Given this list of marker genes GRM2, SRGAP2, SLC24A4, FRMPD4, RACK1 (NCBI Gene Id 90938), NR1D1, HMCN2, LHFPL5, MKKS, SLC38A7, KIF5B, GABRB3, CNTNAP2, ESPN, UNC5C, SPTBN4, GRM5, FSCN1, PRKCB, ZWINT, TPGS1, CLSTN3, AKAP9, ROGDI, EFNB2, MYPN, KIF5A, NEO1, PTPRO, KCNK2, BCL11B, LIMK1, PACSIN1, IFT140 (intraflagellar transport 140), ATP2B2, FKBP4, ARPC2, CTTNBP2, DYNC1H1, DHX36, GRID2, CYFIP1, GNA11, DIP2A, RET, KCNC4, ELMOD3, FCHSD2, NRGN, CDC42, PREX1, BSN, ARHGAP4, LRP4, RAB3A, ZFYVE27, SYNPO, EXOC8, FSCN2, SEPTIN8, GRID1, MAPK8IP3, CASC3, CPEB2 (cytoplasmic polyadenylation element binding protein 2), MYL7, MPDZ, UNC13A, USH1C (USH1 protein network component harmonin), CORO1A, IFT57, SLC18A1, GRIK2, IRX3, TPX2, NPY5R, RGS7, POTEE, TRIM3, NCMAP, SCN1A, SLC1A4 (NCBI Gene Id 6509), BMPR1B, CD3E, ADORA1, INPP5K, DIP2B, MYO15A, SBF1, SSTR5, KNCN, ANG, MARK4, TMEM185A, RAP1A, CTTN, NTRK2, RTN3, DCTN1, NPY1R, CEACAM16, FMR1, CDK5R2, NEFM, URI1, KCNAB1, NRP1, SLC17A8, FLRT1, DCX, ADNP, WDFY3, KNDC1, HOMER1, DRD2, KCNA3, PPP2R1A, MINAR2, CIB1, C4B, KCNIP1, CFAP410, CACNG8, ALDH1A1 (NCBI Gene Id 96075), GSK3B, ATOH7, KCNC1, FKBP15, ATP6V0D1, PROM1, CRB1, MYO1C, KIAA1549, PRKCZ, SEMA6A, DLG3, PLK2, SYT11, CNNM1, DGKI, TACR1, HCN3 (hyperpolarization activated cyclic nucleotide gated potassium channel 3), KIRREL3, TRPM5, IQCJ-SCHIP1 (IQCJ-SCHIP1 readthrough), GRM3, HYCC1, RAB13, DOC2A, ACAP3, CTNNA2, NRCAM, GHRH, GRIN2A, TUBG1, NHERF1, LRP8, MFAP3L, ADAM11, ACTBL2, CHRNE, CRHR2, INHA, CAMK2D, DPYSL3, UBXN2A, DOCK10, WDR19, CCK, NGF, GLRB, CNR2, SCN8A, MAST1, GABRD, DST, NPY4R2, FUBP3, USH2A, CHRM3, GRK4, MAX, TRPV2, CYBB, DDN, HCN4, DCP1A, MAG (NCBI Gene Id 4099), DYRK1A, TANC1, ANK1, GNB5, MPP1, NGEF, SHANK1, DTNBP1, DRP2, CLSTN2, VCAN, GAD2, PPFIA2, ATP1A4, SPAST, CNTN6, CNGA3, RIPOR2, MAF1, ADGRB1, ASS1, PRSS12, WFS1, AMIGO1, MTOR, ATCAY, RDX, ARL3, DRD1 (dopamine receptor D1), LPAR1, VPS13A, GRIN1, HTT, HNRNPU, LUZP1, HTR7, PRRT2, ARC, NMNAT3, EIF4A3, RCVRN, SSTR2, PDZD7, CHRNG, SH2D3C, TPRG1L, MPST, RAB3IP, TH, FYN, PVALB, TRAK1, NECTIN1, CLU, HSP90AB1, CCDC66, KATNB1, CALM3, ANKS1A, MCRS1, SEPTIN6, GHSR, RABGEF1, SLC6A2, CHL1 (NCBI Gene Id 10752), CDK16, CPEB3, SYT7, HRH1, MT3, ARHGAP32 (Rho GTPase activating protein 32), RPS6KB1, SLC6A4, EMB, TUBB4A, MUL1, AP3M2, ZNF385A, EPHA5, EPHB2, SLC2A13, TMIGD1, FSCN3, RAB37, DBNL, NPBWR2, KPNA1, GHRL, HNRNPAB, GRIA1, ELK1, PURA, ATXN10, BAIAP2, PRKAA2, NSF, GABRG3, SCN2B, AP1S1, SEPTIN2, PRNP, ROM1, GLRX3, PACRG, SEZ6, INPP5F, RPTOR, NTS, TMEM230, RGS9 (regulator of G protein signaling 9), BACE1, CHRNB1, LAMA2, TOR1A, TMC2, GPR149, NPTN, GNGT1, CLN3, NF1, KCNK9, FZD4, TMC1, CRMP1, ASIC1, ARHGAP33, NTRK3, POU4F1, DCC, GABRA2, CREB1, PRKN, GUCA1ANB-GUCA1A, TRPM1, LZTS1, NECTIN3, SPTA1, INPP5B, ESPNL, CPNE5, CASR, RGS12, NEFL, RPGRIP1 (RPGR interacting protein 1), KIF13B, INSR, SLC30A3, C4A, SV2A, SLC8A1, TPH2, CX3CL1, SIPA1L1, RAPGEF2, PDYN, GPRIN1, RAC3, DNM3, BRINP2, ACTB, RPGR, STX1B, SNAP25, FAM168B, PLEC, LRP2, RGS6 (regulator of G protein signaling 6), NEK3, SCGN, CHRNB4, PRPH2, KPTN, PHAF1, IGSF9, ADORA3, GABRA1, NEU4, GABBR1, NAPEPLD, FEZ1, HIP1R, NPY6R, GABRB2, ZC3H14, GIT1, SOD1, CRHBP, EMX2, MYO3A, EPHB1, OPN1MW3, CHRNA1, MT-ND1, GFRA1, KLHL14, PDE6G, KCNB2, NFIB, SEMA3A, ALCAM, GABBR2, LMTK3, NRXN1, SCRG1, USP9X, SLC6A1, UCN3, KLHL1, LAMP5, SRCIN1, CNIH3, SLC17A6, IL6ST, NRSN2, RAB21, CNTN2, PIP4K2A, SGCE, UNC13C, MARK1, NCDN, MGARP, OPN4, SYT2, CACNG3, COPG2, LRRC4, VSTM5, SPG11, HTR2C, ITGA8, ACADM, CALCR, SYT4, CEP290, SYT1, HSBP1, CSNK1E, KCND1, SCN11A, KIF4A, SAMD14, MINK1, UNC80 (NCBI Gene Id 84540), CFL1, ZDHHC12, NDEL1, CNGB3, TAOK2, ATXN1L, XRN1, SYAP1, SLC9A5, GRP, BDNF, ITGA2, TRIM46, VTI1A, BASP1, INPP5J, KCNC2, WHRN, SYNDIG1, KIFAP3, STAU2, PALM, BORCS5, HSPG2, CDH13, DNAAF4, NPHP4, VEZT, GCHFR, BIN1, INPP5A, ARHGEF15, NGDN, RAB17, SHISA9, FCGR2B, HTR2B, SAG, CLRN2, PPP1R9B, ARF1, SYT5, STOML3, CLDN5, SCN1B, RPH3A, ACAD9 (acyl-CoA dehydrogenase family member 9), PLEKHG5, GUCA1A, KCNJ2, PSEN1, BTBD8, MAP3K12, PNOC, STRN3 (NCBI Gene Id 29971), SNX14, CTHRC1, APBA1, SLC8A3, CD2AP, ABCA4, GDI1, ADCYAP1, NPBWR1, DLG2, RAB27B, UCHL1, SKOR1, MYO3B, N4BP3, CNTF, BBS7, PTPRQ, TENM4, BMPR1A, SLC38A8, BRAF, ANKS1B, MYO7A, CRYAB, AP3S1, PCDH8, MARK3, OPRD1, DCDC2 (NCBI Gene Id 606719), HTR5A, UNC13B, CAMK2B, VAMP2, NTF3, MLPH, PPP5C, OPN1LW, NXNL1, SNAPIN, RIC3 (RIC3 acetylcholine receptor chaperone), FLRT2, TRPV4, PALLD, PAK1, GPM6A, VPS35, RASGRF1, STMN4, SLC1A3, HTR1E, LRIT1, OPHN1, OPN1MW2, ENO2, BECN1, KCNK1, EPB41L3, TGFB2, KIF20B, PCSK2, CDH8, ALS2, TRPA1, CPLX1, PPEF2, LRFN3, FXR2, MAP6, MYO1D, MYOC, APBA2, RPGRIP1L, OCRL, RELN, NFASC, JPH4, GNA12, PRPH, OPN1SW, PTGS2, AQP1, MICALL2, CDH23, BRINP1, LPAR3, C9orf72, ULK1 (unc-51 like autophagy activating kinase 1), CETN1, NPY4R, ELOVL5 (ELOVL fatty acid elongase 5), GABRA4, APP, PTPRS (protein tyrosine phosphatase receptor type S), FXR1, MYH10, SNPH, LYNX1, KCNA4, RUFY3, KCNK4 (NCBI Gene Id 50801), TNN, POTEKP, KIF5C, SYT8, ITGA3, DTNB, CLDN11, PENK, CHRND, NPFF, BLOC1S3, SDCCAG8, GPR179, SLC8A2, HOMER2, IGSF9B, OPRM1, MACO1, PRKAR2B, RGS17 (regulator of G protein signaling 17), EPHA6, CHRNA9, KCNE3, PRCD, BLOC1S6 (biogenesis of lysosomal organelles complex 1 subunit 6), RNF112, MDGA1, WASF1, SPOCK1, BLOC1S4, SEMA4F, NSG2 (neuronal vesicle trafficking associated 2), PCDHGB1, ABR, OXT, BBS4, TP63, KIF3B, GNAT2, GDPD5, CEP250, AVP, LRRC7, ARFGEF2, CADM2, KIF17, MYRIP, SYBU, BLOC1S2, AP3B2, KLHL20, PJVK, ADGRL1, OPA1, SPTBN5, NF2, CLCN3, SLC18A3, AP3D1, GNAQ, BRINP3 (BMP/retinoic acid inducible neural specific 3), EPHA7, CALM2, SHANK3, DCTN2, SLC38A1, NLGN4X, NECAB2, ANKRD27, CX3CR1, GLRX5, GABRA3, KCNC3, APOE, STMN2, TENM1, OPRK1, NTF4, PSD, PCLO, RPL28, RHOA, MORN4, TSHZ3, GOPC, GRIA3, DOCK7, TAC1, PRKAA1, TSC22D4, SSNA1, RAB5A, CDHR1, UCN, CYP46A1 (cytochrome P450 family 46 subfamily A member 1), CLSTN1, ARHGAP44, CHRNA10, MYOT, FZD5, PLS1, PTPRN, TULP1, BRSK1, NDRG2, EXOC6, LDLRAP1 (low density lipoprotein receptor adaptor protein 1), CLASP2, PQBP1, STAT1, UNC5A, ATP6AP2, CACNG2, GUCA1C, ARF4, PCSK1, RHOC (NCBI Gene Id 389), EPHA3, RHO, FARP1, TTLL7, ABHD12, SLC1A2, RANGAP1, PAFAH1B1, PPT1 (palmitoyl-protein thioesterase 1), LHFPL4, GNG13, RARA, RBM3, ARHGEF7, NUMA1, ITSN1, KLC3 (kinesin light chain 3), BLOC1S5, DAG1, VAMP3, DAGLA, MYC, ADORA2A, EPS8, PICK1, SLC12A2, MADD, NRP2, APOD, UHMK1, CTSZ, SERPINF1, ABI3, DSCAM, FAT3, TACR3, ROBO1, SETX, GABRE (gamma-aminobutyric acid type A receptor subunit epsilon), SLC18A2, ADAM22, STRN4 (NCBI Gene Id 29888), PDE6A, HTR2A, ADGRV1, IGHMBP2, NAV1, KIF3A, IQCB1, CYFIP2, ROR2, NGFR, KLC1, FLNA, CACNA1C (NCBI Gene Id 775), ITGB1, INSRR, MAGI2 (NCBI Gene Id 9863), TBC1D24, ERO1A, CBL, GNRH1, VIP, APBB1, RTN4RL2, GRIK3, ZPR1, ITGA4, PALS1, USH1G, BCAR1 (NCBI Gene Id 9564), PDE6H, LCA5, KCNB1 (potassium voltage-gated channel subfamily B member 1), ABL1, LYPD6, ARL8B, RAB27A, CPEB1, FBXO7, PRLHR, CAMK2A, GLDN, GPR37, NLGN1, ANKRD24, GNAZ, PLK3, SFPQ, ADRA2A, HRH2, TWF2, CLRN1, GAD1, HAPLN2, SPTBN1, MTMR2, PCDH9, ATG5, POTEF, PPP1CC, STAU1, COPA, LGI3, GABRG2, GRXCR1, NLGN2, EIF4EBP2, TPH1, OSBP2, FRMD7, GRIN3A, ATL1 (NCBI Gene Id 6681), CBARP, IFT20, ATP8B1, CHRM2, RP1, KCNQ1, AVIL, KCNQ2, GPHN, NCAM2, SMO, PRKCG, DLG4, BBS2, TSGA10, CYGB, ABHD17A, CD40, BRSK2, EPM2A, SNCB, GRIA4, KCNN1, SHANK2, MARK2, PPFIA1, MAPT, KIF1B, ABI1, KCNN3, CNTN4, VAMP7, RGS14, STRC, RTN2, FBXO2, DNM2, CYP17A1, TENM3, CDKL5, IMPG1, CNGB1, SYNPR, GRK1, CNTN1, MAP9, SAMD4A, MICAL1, KIF1C, P2RX6, COMT, NSG1, DVL1, PTGDR2, MAP1S, AGTPBP1, IGF2BP1, DRD4, ADCY4, RAB8A, TOPORS, RP1L1, SLC32A1, SNAP23, PTCH1, SMN1, UBB, AHCYL2, GNB1, DTNA, IGF1R, ZMYND8, HTR3D, MYH14, KIF21B, CALM1, NCF1, PLXND1, PTK7, CNTN5, CETN3, TTC8, DMWD, CAMK2G, LRIT3, STON2, TSGA10IP, GPER1, GIPC1, SARM1, KCNQ5, ROBO2, EEA1, EXOC4, TGFB1, ERC2, CYTH2, STX4, SLC4A10, PCDH15, DYNLL1, ARMCX3, MAP4, SORBS2, BLOC1S1, ABITRAM, ABHD17B, ROR1, RTN4R, CRHR1, DISC1, CRIPT, SYNJ1, NMU, HTR3B, APBA3 (amyloid beta precursor protein binding family A member 3), CHRNA5, CHRFAM7A, PIEZO2, ADCY10 (adenylate cyclase 10), LYAR, SYT13, SPA17, ABHD13, TENM2, TANC2, POC5, AP3B1, TRPV1, TRPC5, NCS1, ELFN1, HMGB1, PLXDC1, SRD5A1, GNAI2 (G protein subunit alpha i2), PGRMC1, NTSR1, MAP1B, NEFH, CDK5, NRSN1, HTR1F (5-hydroxytryptamine receptor 1F), STRN, CD200, BMPR2, CERKL (NCBI Gene Id 394232), GABRB1 (NCBI Gene Id 2560), TRIOBP, SLC38A2, RBM8A, CETN2 (NCBI Gene Id 812), RTN4, CAPN2, PALMD, SORCS2, GNB3, PIEZO1, PARD3, BCR, CPT1C, MCHR1, SSTR4, FGF13, AZIN2, RGS11, STXBP1, PPP3CA, TMEM108, MYCBP2, ARL8A, GIGYF2, GLRA1, LRIG2, VPS16, APBB2, NDFIP1, MBP, PKHD1L1 (NCBI Gene Id 93035), TSPEAR, RGS7BP, BGLAP (bone gamma-carboxyglutamate protein), HTR6, ANK3, ATAT1, NAP1L4 (nucleosome assembly protein 1 like 4), IL1RAPL1, ADGRL3, ADAM21, SYN1, CIB2, DMD, KCND3, EPHA4, SSTR1, ANK2, GARS1, KCNIP2, GRIA2, AAK1, FBXW11, PUM1, HSPB1, AP3M1, HTR1D, MERTK, ADAM10, HTR3E, VIM, HRH3, CADM1, CPLX4, HCN2, KCND2, SLC4A7, BAG2, ERMN, CHRNB3, CALB2, ELAVL4, ATP7A, CNGA1, AKAP5, IQGAP1 (NCBI Gene Id 8826), SPATA7, STMN3, STRCP1, CDH2, MME, GRM1, PDC, TSPOAP1, GRIN2B, CLIC5, SACS, MAP2K1, CHRM5, HOMER3, TRAK2, LRRTM1, BPTF, PTGS1, VAMP1 (NCBI Gene Id 6843), HTR4, PPP1CA, EPHA8, CCSAP, NPHP1, CYBA, ATG16L1, DAB2IP, YKT6, NIN, TPBG, CRH, SNCG, SLC12A6, NPR2, ATF4, RGS8, SMN2, FLRT3, SSTR3, ACTR10, GRM6, PTEN, GLRA3, CHRNA4, HAP1, EXOC7, SIRT2 (sirtuin 2), ZDHHC5, NEGR1, NRDC, NSMF, RTN1 (reticulon 1), CHAT, IFT122, ACTG1, PTK2B, SLC4A8, SCN2A, IL31RA, TIAM2, ADCY9, MAP7, SHTN1, PEX6, NTRK1, CLCN2, TMEM151A, LLGL1, RPS6 (NCBI Gene Id 92956), POTEJ, STX1A, CRTAC1, ABI2, SYP, GRIPAP1, GSK3A, P2RY1, GNG3, KIF1A, SIGMAR1, CAD, TXNRD2, SLC1A1, OTX2, DPYSL5, DLG1 (discs large MAGUK scaffold protein 1), TMEM266, NEXN, PRR7, BRD1 (bromodomain containing 1), TBCC, CHRM4, TMEM222, OLFM1, RASGRP2, FLOT2, PINK1, MAPK8IP1, CPNE6, UFL1, MAK, BOC, KCNN4, CABP4, RGS9BP, AGO2, NTNG2, KIFC2, CHRNA2, DSCAML1, MYO9A, MAP7D2, EPS8L2, CALB1, EPHB3, FZD3, RAB39B, GUCY2D, KCNH1, STMN1, L1CAM, PNLIPRP2, CDC14A, SMURF1, RAC1, LRRK2, SSH1, CNIH2, ATP1A2, SHISA7, TRIM9, KCNA1 (NCBI Gene Id 729214), CPEB4, ATP1A1, SRSF10 (NCBI Gene Id 89048), NCAM1, GOT1, MAP1A, GPR19 (G protein-coupled receptor 19), GABRA5, CHRNA6, SEPTIN11, SCN9A, HTR1B, TERF2, SLC12A5, CCR2, DNAJB1, CACNG7, RAP1GAP, FEZ2, SYNGAP1, HCN1, COBL, DHRS3, NPY, PTPRF, CMKLR2, PI4K2A, HIF1A, FAM107A, CHRNA3, KCNA6, PDE4B, SEPTIN14 (NCBI Gene Id 378074), MAP2, PCDHB15, HTR3C, SLC5A7, HTR3A, EXOC3, HPCA, BAALC, PHLPP2, HRH4, LOXHD1, EYS, TRAPPC4, CAPRIN1, ITPKA, CALCA, KIRREL1, GRM7, KLHL24, IFT56, GRK7, LRRC4B, MAGEE1, BNIP3, GCH1, MPP2, HTR1A, EPHB6, SLC6A6, SH3KBP1 (NCBI Gene Id 94010), HSP90AA1, LMTK2, PARK7, NMNAT2, GRXCR2 (glutaredoxin and cysteine rich domain containing 2), PPP1R9A, UPF3A, CCDC120, ATP13A2, CPLX3 (NCBI Gene Id 594855), ARPC3, GAP43, DOCK4, PTPN9, KCNA2, TPRN, DNER, KIF21A, BSG, ZNF804A, CNR1, TMIGD2, OPRL1, ADCY8, FAM161A, AUTS2, HDAC6, OPN3, KCNN2, GUCA1B, TUBB3, THY1, PTCHD1, ROBO4, SLC6A3, SPG7, CAMKK2, CHRNB2, PDE6B, SLC30A1, NOS1, CXADR, PDLIM4, ADCY6, SLC17A7, LZTS3, CTNND2, ASIC2, NETO1, AURKA, PTBP2, CAMK2N1, MYO5A, GNAO1, ARR3, ATP1A3, KCNQ3, NMB, EPHA10 (NCBI Gene Id 440580), STX3, GNAT1, OPN1MW, SNCA, PCDHB13, AP3S2, RD3, CDK5R1 (NCBI Gene Id 8851), NEURL1, SBF2, RNF6, IFT52, SHISA6, ABHD17C, DBN1, SEPTIN4, AMFR, ROBO3, PRR12, MYO10, LGI1, C1QL1, PSD2, PCARE, ATP2B3, ACTN2, NRN1L, PLPPR1, EEF2K (NCBI Gene Id 29904), GUCY2F, RIT2, POTEI, SLITRK2, CACNA1F, SRD5A2, GRIP1, RIN3, TMEM237, CHRM1, KCNAB2, GABRG1, OMP, P2RX3, SHISA8, RSPH9, CHRNA7, CPLX2, CNTNAP1, SCN10A, OPN5, MAPK8, ACTL8, WDR47 (WD repeat domain 47), ADCY2, EVX1, GABRA6, AGBL4, CNTN3, here is a description of the gene set: studied in species Homo sapiens A prolongation or process extending from a nerve cell, e.g. an axon or dendrite. Human Gene Set: GOCC_NEURON_PROJECTION